Given this list of marker genes ZDHHC7, CFD, RAB10, CHP1, MPST, MYL6, GSE1, PTPN12, SECTM1, FTH1, CDKN1A, PEA15, SGPL1, NAMPT, C3AR1, DENND3, GNAI2, TBC1D8, NOTCH2, RGS2, SRXN1, VAMP3, LILRB3, DPYD, VCL, FEZ2, LSP1, GNGT2, UBE2J1, CYP1B1, LINC00968, MAP3K8, CTSZ (cathepsin Z), SH2B3, ARHGAP26, STXBP2, SAP30, RNF149, AP3B1, TTYH3, DDIAS, CAPNS1, CCDC50 (coiled-coil domain containing 50), TRAK1 (trafficking kinesin protein 1), LY96, YWHAG, SETBP1, GUCD1, EFHD2, PDLIM1 (PDZ and LIM domain 1), ARPC1B, ENG, FNDC3B, RNF144B, GSTO1, GLUL, GNLY, EPAS1, ADAM8, TMEM154, PPP4C, RTN1, CD9, SLC6A6, PHKB, RAB27A, SLC22A15, MTHFD2, DUSP22, CEBPB, SLC7A7, PIP5K1B, CYBA, ZNF710, FUCA2, COPA, SESTD1, SRC, CTSA, HERPUD1, HLA-DPA1, DNAJB11, TKT, OSBPL5, DGAT2, CEBPD, TNFSF13, B4GALT5, HVCN1, USP15, NAGA, NBN, AIF1, REPS2 (NCBI Gene Id 9185), UBE2E1, TMCC3, SSR3, SYT17, PLXND1, CARD9, SPOCK1 (SPARC (osteonectin), cwcv and kazal like domains proteoglycan 1), FUT7, GRB2, RASGRP4, GABARAP, LTA4H, GALC (NCBI Gene Id 2581), WDFY4, ARSB, GRAMD4, CLTA, STS, MPP1, TM9SF2, PTGS1, IL18R1, LILRA6, GUCY1B1, C9orf72, CAT, SLC31A2, RALB, WDR11, ACTN4, DYSF, PLEKHG3, MAP3K3, PDE4A, ATP6V0B, TMEM59, CATSPER1, H2AC6, HAL, MIR22HG, GSTP1, CD244, CAPG, SND1, STOM, GDI2, MEIS1, CLTC, GALNT10, NFIL3, EMP3, BCKDK, TMED5, TM6SF1, IRF2, DGKG, B3GNT5, REL, RHOC, AHR, PDGFC, RAB8A, SNAP23, PLEKHO1, NAGK, JAK2, POU2AF1, PLSCR1, AKIRIN2, PGD (phosphogluconate dehydrogenase), TPST2, SLC37A2, TGFB1I1, TEP1, OAZ2, SLC15A4, ACTB, ZNF385A, ZMPSTE24, RNF130, SLFN11, TLR6, SH3BGRL3, CSF2RB, RHOU, PRR5L, TMEM40, DUSP5, FABP5, SCO2, QSOX1, ACER3, CDK2AP1 (cyclin dependent kinase 2 associated protein 1), ADAMTSL4, FTH1P5, ATP2A2, TP53INP1, LYST, GSR, LAP3, MCTP1, LIMS1, ANXA4, here is a description of the gene set: Human Gene Set: GSE11057_NAIVE_CD4_VS_PBMC_CD4_TCELL_DN Genes down-regulated in comparison of naive T cells versus peripheral blood mononuclear cells (PBMC). Microarray deconvolution is a technique for quantifying the relative abundance of constituent cells in a mixture based on that mixture's microarray signature and the signatures of the purified constituents. It has been applied to yeast and other systems but not to blood samples. Here we test the ability of this technique to determine the fractions of subsets of memory T cells in peripheral blood mononuclear cell (PBMC) samples. from publication Abbas AR, Wolslegel K, Seshasayee D, Modrusan Z, Clark HF (PMID 19568420) species: Homo sapiens